Given this list of marker genes Plscr1, Ubac2, H2-Q7, H2-T23, Agpat3, Sptlc2, Nkg7, Gng5, Ifi47, Samhd1, Rab11a, Stat1, Rnh1, Itm2b, Unc119, Klre1, Cotl1, Actg1, Gimap7, Psme2, Igtp, Ifngr1, Hopx, Gatad2a, Ptrhd1, Psmb8, Borcs7, Gnb2, Tap1, Ccl5, Plaat3, Cycs, Hnrnpd, Cdk7, Psmb10, Ube2e3, Psma2, Abracl, Gzmb, Prf1, Ncr1, Arpc1b, Adss1, Emc8, Rap1a, Tap2, Irf8, Klrg1, Gzma, Lilrb4b, Zbp1, Irf1, Gimap4, here is a description of the gene set: Cytokines mediate cell-cell communication in the immune system and represent important therapeutic targets. A myriad of studies have highlighted their central role in immune function, yet we lack a global view of the cellular responses of each immune cell type to each cytokine. To address this gap, the authors created the Immune Dictionary, a compendium of single-cell transcriptomic profiles of more than 17 immune cell types in response to each of 86 cytokines (>1,400 cytokine-cell type combinations) in mouse lymph nodes in vivo. A cytokine-centric view of the dictionary revealed that most cytokines induce highly cell-type-specific responses. For example, the inflammatory cytokine interleukin-1β induces distinct gene programmes in almost every cell type. A cell-type-centric view of the dictionary identified more than 66 cytokine-driven cellular polarization states across immune cell types, including previously uncharacterized states such as an interleukin-18-induced polyfunctional natural killer cell state. species: Mus musculus Genes positively differentially expressed in cell type: NK cell upon treatment with cytokine: IL-27 in mouse lymph nodes in vivo. from publication Cui A, Huang T, Li S, Ma A, Pérez JL, Sander C, Keskin DB, Wu CJ, Fraenkel E, Hacohen N (PMID 38057668) Mouse Gene Set: CUI_NK_CELL_IL27_RESPONSE_UP